Given this list of marker genes H2AC20, H2AC14, H2AZ2, H2BC12L, H2AX, H2BC15, H4C1, H2BC12, H2BC21, H3C15, ORC1, H2BC3, KPNA6, KPNB1, H3C1, ORC3, H2AC7, H2AJ, H3-3A, H2BC5, H2AC4, H2BC11, H2BC4, H2BC17, H2AC18, ORC4, H2BC14, KPNA1, H2AC6, H2BC26, ORC6 (NCBI Gene Id 23594), H2BC9, ORC5, ORC2, H2BC13 (NCBI Gene Id 8340), H2AB1, H2BC1, here is a description of the gene set: Reactome Pathway: Assembly of the ORC complex at the origin of replication species: Homo sapiens Human ORC1 can associate with DNA origin of replication sites independently of other origin of replication complex (ORC) subunits. ORC1 localizes to condensed chromosomes during early mitosis (M phase) and serves as a nucleating center for the assembly of the ORC and, subsequently, the pre-replication complex. ORC1 remains associated with late replication origins throughout late G1. Upon S phase entry, ORC1 undergoes ubiquitin-mediated degradation, leading to dissociation of the ORC from chromatin.<br><br>Most human replication origins contain guanine (G)-rich sequences which may form G-quadruplex (G4) structures and these G4 structures may mediate the recognition of replication origins by ORC1. Besides binding to nucleosome-free replication origin DNA, ORC1 interacts with neighboring nucleosomes, in particular with nucleosomes containing histone H4 dimethylated at lysine 21 (H4K20me2 mark), which is enriched at replication origins. Binding of ORC1 to H4K20me2 facilitates ORC1 binding to replication origins and ORC chromatin loading.<br><br>ORC1 binding sites are universally associated with transcription start sites (TSSs) of coding and non-coding RNAs. Replication origins associated with moderate to high transcription level TSSs (belonging to coding RNAs) fire in early S phase, while those associated with low transcription level TSSs (belonging to non-coding RNAs) fire throughout the S phase.<br><br>ORC2 forms a heterodimer with ORC3, which is a prerequisite for the association of ORC5 and, subsequently, ORC4. ORC1 binds to the ORC(2-5) complex in the nucleus to form a stable ORC(1-5) complex. ORC1 is necessary for the association of the ORC(2-5) complex to chromatin. The ORC(2-5) complex exhibits a tightly autoinhibited conformation, with the winged-helix domain (WHD) of ORC2 completely blocking the central DNA-binding channel. Binding of ORC1 remodels the WHD of ORC2, moving it away from the central channel and partially relieving the autoinhibition. ORC6 associates with the ORC(1-5) complex to form the ORC(1-6) complex. The association of ORC6 with the ORC(1-5) complex is weak and it frequently does not co-immunoprecipitate with the other ORC(1-5) subunits. ORC4 is the only ORC(1-5) subunit that was shown to directly bind to ORC6. Some ORC6 mutations reported in Meier-Gorlin syndrome were shown to interfere with ORC6 incorporation into the ORC. part of: Assembly of the pre-replicative complex